The following is a description of a gene set: Human Gene Set: GOBP_ALDITOL_METABOLIC_PROCESS The chemical reactions and pathways involving alditols, any polyhydric alcohol derived from the acyclic form of a monosaccharide by reduction of its aldehyde or keto group to an alcoholic group. studied in species Homo sapiens, and this is the list of marker genes: LEP, GK, MOGAT2, SORD, GK2, TPI1, DGAT2, GPD2, ANGPTL3, PCK1, PGP, TKFC, GK5, FKRP, COQ3, PLA2G4A, MOGAT3, COQ2, PCK2, GOT1, GALK1, MOGAT1